The following is a description of a gene set: Genes predicted to be targets of miRBase v22 microRNA hsa-miR-12116 in miRDB v6.0 with MirTarget v4 prediction scores > 80 (high confidence targets). Human Gene Set: MIR12116 species: Homo sapiens from publication Chen Y, Wang X (PMID 31504780), and this is the list of marker genes: DONSON, ZNF148, LHFPL6, NUP210L, DIPK1A, KIAA1143, NIN, USP45, MYO9A, PRPS2, HNRNPH3, GLUD1, PIKFYVE, CETN3 (NCBI Gene Id 1070), TANK, ITGB8, ZBTB41, ZSWIM7, TAF5L, PLLP, ATP11C, SWT1, MIR1915HG, LRRTM2, IFT81, NEK7, ZNF407, UTRN, VIRMA, CDC5L, NHLRC2, ZDHHC15 (zinc finger DHHC-type palmitoyltransferase 15), CFAP47, PDXDC1, RFTN2, WFDC8, SCAI, DDX3X, CBX2, PRKAA1, PRKD1, ACSL4, CREB5, LRRC39, GNRHR, PUS3, CNBP, NAP1L1, EREG (NCBI Gene Id 2069), EIF2AK3, SLC25A21, RBM4, PI15, CXCR5, RORA (NCBI Gene Id 6095), CMTM2, ZNF131, SLC52A1